The following is a description of a gene set: Genes up-regulated in a linear fashion in CD34+ cells upon increasing activity levels of STAT5A; predominant long-term growth and self-renewal phenotype. studied in species Homo sapiens The level of transcription factor activity critically regulates cell fate decisions, such as hematopoietic stem cell (HSC) self-renewal and differentiation. We introduced STAT5A transcriptional activity into human HSCs/progenitor cells in a dose-dependent manner by overexpression of a tamoxifen-inducible STAT5A(1*6)-estrogen receptor fusion protein. Induction of STAT5A activity in CD34(+) cells resulted in impaired myelopoiesis and induction of erythropoiesis, which was most pronounced at the highest STAT5A transactivation levels. In contrast, intermediate STAT5A activity levels resulted in the most pronounced proliferative advantage of CD34(+) cells. This coincided with increased cobblestone area-forming cell and long-term-culture-initiating cell frequencies, which were predominantly elevated at intermediate STAT5A activity levels but not at high STAT5A levels. Self-renewal of progenitors was addressed by serial replating of CFU, and only progenitors containing intermediate STAT5A activity levels contained self-renewal capacity. By extensive gene expression profiling we could identify gene expression patterns of STAT5 target genes that predominantly associated with a self-renewal and long-term expansion phenotype versus those that identified a predominant differentiation phenotype. from publication Wierenga AT, Vellenga E, Schuringa JJ (PMID 18779318) Human Gene Set: WIERENGA_STAT5A_TARGETS_GROUP2, and this is the list of marker genes: ABCA1, GADD45B, HOXB5, LAMP3, COCH (NCBI Gene Id 23718), KLF2, CKAP4, CCL2, PSAT1, PLEKHH3, GALC, CA2, FPR3, EGFL6, CCL5, RGS1, ANTXR2, CXCL10, PLAU, PHTF2, MOB3B, CCR7, CSF2, GNPTAB, BHLHE40, CCL22, PRDM8, STAP1, EMP1, COL6A1, GABARAPL1, SLC2A14, CLEC4A, SOCS2, P3H2, BTG2, OLR1, CCL3, CXCL8, TRAF1, KLF6, TSC22D2, FAM241A, CD1B, SQSTM1, CD83, TUBB2B, GPR65, MAPK13, IL7R, AK3, RNF217, SPP1, NFIL3